The following is a description of a gene set: studied in species Mus musculus Mouse Gene Set: GOBP_SPINAL_CORD_PATTERNING The regionalization process that regulates the coordinated growth and establishes the non-random spatial arrangement of the spinal cord., and this is the list of marker genes: Smo, Sufu, Chrd, Ift88, Nkx2-2, Gli2, Rfx4, Dbx1, Evx1, Tulp3, Reln, Gdf11, Foxn4, Dll4, Intu, Fuz, Pax6, Ascl1, Dmrt3, Gli3, Ift122, Sox1, Rab23, Shh, Lhx3